Given this list of marker genes STAT4, PSEN1, HLX, SOCS5, BRD4, CD80, IL4R, TBK1, RELB, CD81, ATP7A, EOMES, IL18R1, LGALS9, SLC11A1, GATA3, ZBTB7B, PCK1, RARA, JAK1, BCL3, HMGB1, SHB, STAT3, CD69, IL27, JAK3, IFNG, FOXP1, RORC, F2RL1, MYB, APBB1IP, LGALS1 (NCBI Gene Id 3956), RORA, CD74, SOCS3, ENTPD7, IFNB1, HLA-DRB1, ITGAL, ICOS, IL12RB1, IFNW1, TMEM98, IL6ST, IRF4, IFNA21, ZFPM1, SLAMF6 (NCBI Gene Id 114836), OPA1, GPR183, IL21, BCL6, TBX21, ANXA1, PTGER4, SPN, IFNL1, BATF, BRD2, JUNB, SEMA6D, IFNA1, IL6, HLA-DRA, HAVCR2, TNFSF4, PIK3R1, IFNE, NFKBIZ, RC3H1, IFNA16, SMAD7, FCER1G, KMT2A, PLXNA1, NFKBID, ASCL2, IL23A, RAB27A, EP300, CCL19, CRACR2A, IFNA4, IFNA2, IFNA10, CD86, PDP2, LCP1, IFNA6, ICOSLG, IFNA5, IFNA7, EIF2AK4 (eukaryotic translation initiation factor 2 alpha kinase 4), FOXP3, HLA-DMB, CEACAM1, TNFSF18, FCGR2B, LY9, IFNA14, GPR65, NCKAP1L, IFNK, IFNA8 (NCBI Gene Id 95818), IL2, LGALS3, LEF1, CD1C, IL23R, TSC1, ZC3H12A, TYROBP, MTOR, MDK, CLEC4E, LOXL3, SEMA4A, FGL2, IFNA17, ICAM1, RIPK2, NLRP3, IL18, STAT6, STAT5A, CD46, LILRB1, IL6R, MEN1, PRKCZ, TREM2, RC3H2, IL12B, MIR21, TP53, CLEC4D, MALT1, here is a description of the gene set: The change in morphology and behavior of a mature or immature T cell resulting from exposure to a mitogen, cytokine, chemokine, cellular ligand, or an antigen for which it is specific, leading to the initiation or perpetuation of an immune response. Human Gene Set: GOBP_T_CELL_ACTIVATION_INVOLVED_IN_IMMUNE_RESPONSE species: Homo sapiens